The following is a description of a gene set: Mouse Gene Set: GOBP_REGULATION_OF_CLATHRIN_COAT_ASSEMBLY studied in species Mus musculus Any process that modulates the frequency, rate or extent of clathrin coat assembly., and this is the list of marker genes: Gak, Snap91, Epn1, Syt11, Caly, Dnajc6, Hip1r